Given this list of marker genes FLNB, GLB1, RSPRY1, COMP, NF1, SH3PXD2B, GALNS, B3GALT6, GNPTAB, AGA, RINT1, NPR2, SERPINF1, PYCR1, COL11A2, TMCO1 (NCBI Gene Id 54499), GORAB, COL2A1, GUSB, CCN6, NEPRO, HGSNAT, PRKG2, ARSK, PLCB3, DYM, FUCA1, here is a description of the gene set: Human Gene Set: HP_BEAKING_OF_VERTEBRAL_BODIES Anterior tongue-like protrusions of the vertebral bodies. Beaking of vertebral bodies studied in species Homo sapiens